The following is a description of a gene set: Enables the transfer of a UDP-N-acetylglucosamine from one side of a membrane to the other. N-acetylglucosamine is a substance composed of N-acetylglucosamine, a common structural unit of oligosaccharides, in glycosidic linkage with uridine diphosphate. Human Gene Set: GOMF_UDP_N_ACETYLGLUCOSAMINE_TRANSMEMBRANE_TRANSPORTER_ACTIVITY species: Homo sapiens, and this is the list of marker genes: SLC35B4, TMEM241, SLC35D1, SLC35D2, SLC35A3